Given this list of marker genes Atf6b, Tfcp2l1, Slc16a14, Ctnnd1, Hoxb9 (NCBI Gene Id 15417), Srcap, Exd2 (exonuclease 3'-5' domain containing 2), Zmym3, Pth, Tenm2, Myadm (myeloid-associated differentiation marker), Dgkk, Adgrb1, Carmil1, Ark2c, Pak2, Alyreffm17, Prxl2a, Igf1r, Cnot2, Plagl1, Phlpp2, Zbtb45, Fchsd2, Gsx1, Eif4ebp2 (eukaryotic translation initiation factor 4E binding protein 2), Rnf13, Ppp6r1, 0610030E20Rik, Tmem141, Ctr9, Vegfa, Alyreffm15, Rgs7bp, Coro1c, Ckmt2, Alyreffm16, Gcnt1, Alyreffm13, Tspan18, Baz2a (bromodomain adjacent to zinc finger domain, 2A), Sec14l3, Prkar2b, Anks1, Nid1 (NCBI Gene Id 268621), Nr1d1, Ifi213, B4galt1, Alyreffm14, Eif4b, Rab14, Klhl29, Nmnat2, Thra, Sox6 (NCBI Gene Id 20679), Anxa2, Bsn, Arid1a, Hyls1, Flot2, Fignl2, Dcaf8l, Synj2bp, Gap43, Sv2c, Nt5dc3, Wdtc1, Xkr4, Tmem79, Alyreffm10, Ptbp2, Tpst2, Luzp1, Ldlrad3, Fbxl17, 4921536K21Rik, Zfp169, Hsh2d, Hook3, Zfp950, Socs3, Usp17la, Igf1, Rgs5, Ptpn14, Fam222b, Phactr2, Prr3, Plxna2, Tnip3, Prickle2, Trim23, Pcnp, Dapp1, Dpysl5, Zdhhc9, Zfp385a, Gstz1, Clvs1, Ncs1, Ctbs, Alyreffm11 (NCBI Gene Id 100861880), Col11a1, Snx27, Cd200l1, Ost4, Rab5b, Gm15816, Cd86, Cdc27, Specc1, St6galnac3, Klf3, here is a description of the gene set: from publication Chen Y, Wang X (PMID 31504780) Genes predicted to be targets of miRBase v22 microRNA mmu_miR_7057_5p in miRDB v6.0 with MirTarget v4 prediction scores > 80 (high confidence targets). studied in species Mus musculus Mouse Gene Set: MIR_7057_5P